Given this list of marker genes Ywhaz, Lama5, Clasp1, Ptprf, Dnm1l, Zfp804a, Mark1, Sybu, Ptpn1, Gripap1, Drd2, Dmpk, Cdh4, Actn4, Actr3, Six1, Caprin1, Adgrb1, S100a10, Epha7, Unc13b (NCBI Gene Id 230089), Lrrk2, Arhgap33, Chrnb1, Cldn34b2, Grm5, Nedd8, C5ar1, Wasf2, Gabra2, Cnksr2, Tln2, Cap1, Cldn11, Tenm3, Epha2, Fam107a, Gjc1, Egln1, Ppfia3, Amigo3, Glrb, Lrp8, Anapc2, Tiam1, Cldn12, Abi2, Tnf, Thy1, Homer1, Erbb2, Nrn1, Cacna1a, Cldn10, Septin7, Slit2, Snapin, Cntnap1, Cldn1, Setd5, Epb41l5, Asic1, Cldn19, Rab29, Prickle1, Cldn22, Cntn5, Ror2, Xlr3b, Arf4, Nbea, Trim47, Ptpro, Amot, Ptpra, Prkca, Pfn2, Rab39b, Sez6, Efna5, Dbn1, Wdpcp, Tgfbr1, Pdzrn3, Stau1, Myo5a, Nrxn2, Itga3, Plxna2, Fbxo45, Nr1h4, Plxna3, Itgam (NCBI Gene Id 16409), Picalm, Nefl, Flcn, Insyn1, Lsr, Arhgap6, Ace2, Vhl, Lin7a, Tnc, Kif5b, Samt3, Pcdhgc5, Grip2, Gpc4, Zdhhc17, Itgb1, F11r, Ogt, Cpeb3, Gabra5, Xlr4a, Rac1, St8sia2, Grn, Sncg, C3, Colq (NCBI Gene Id 382864), C1ql3, Pard3, Hspa8, Sdcbp, Ctbp2, Chmp2b, Apbb1, Il1rapl1, Sema4c, Gphn, Cacna2d2, Ocel1, Ptprs, Asb17, Sdk2, Plxnb1, Fyn, Htr4, Cdh20, Arhgap39, Asap1, Nrg2, Prmt3, Myh9, Tjp3, Lgmn, Tgfb1, Prtn3, Rab3a, Cdkl5, Nrg1, Gjb2, Lypd11, Nfatc4, Epha5, Amigo1, Sptb, Gsg1l, Ube3b, Igsf21, Srpx2, Pclo, Ildr1, Pard6a, Whamm, Nphp4, Plec, Slc12a5, Myo6, Pdlim5, Gja5, Slc39a9, Rock1, Camk2b, Lrp1 (NCBI Gene Id 16971), Cd177, Nptxr, Nedd4 (NCBI Gene Id 639396), Pip5k1a, Jup, Lrrc4, Cadm4, Arc, Sptbn4, Vangl2, Oxtr, Plxnb3, Rapgef1, Clasp2, Aplnr, Zfp365, Pdpk1, Malat1, Nf2, Mtss1 (MTSS I-BAR domain containing 1), Csf1r, Sorbs2, Actn3, Rer1, Akap5, Lrrtm4, Cldn18, Il10, Sort1, Rap1b, Rims3, Rph3a, Usp9x, Col16a1, Clstn3, Ppfia1, Pls3, Ctnna1, Xirp2, Numb, Lrrn3, Il10ra, Mapk14, Asic2 (NCBI Gene Id 637557), Micall2, Hdac7, Ank3, Gabra3, Lingo4, Nrp1, Rapgef4, Cdh11, Lamc1, Lims1, Ghsr, Src, Adgrl2, Fgfr1, Snap91, Rhob, Hopx, Ppfibp2, Cx3cr1, Mylk3, Cdk5, Nf1, Prickle2, Slit1, Smad3, Oxt, Ache, Ppm1f, Pin1, Adgrb2, Elavl2, Srgap3, Psd, Sncb, Cdh5, Cntnap2, Lats1, Adnp, Kif1a, Rims2, Dvl1, Sema4a, Slc30a1, Shisa6, Grin1, Mpz, Palld, Ccdc39 (NCBI Gene Id 99728), Dock10, Agt, Grin2a, Igf1r, Zdhhc15 (zinc finger, DHHC domain containing 15), Abl2, Syn1, Rhoa, Lrtm1, Abi3, Cd47, Chrna7, Sdc4, Ntn1, Map4k4, Clstn2, Ptk2, Rhoc, Ldb1, Ephb1, Xlr4b, Ptpn11, Cdh10, Cdh6, Tnr, Arhgap22 (NCBI Gene Id 239027), Mapt, Adgrl1, Zdhhc8, Adgre5, Rdx, Stk38l, Dok7, Podxl, Musk, Ghrl, Pak3, Als2, Cript, Vmp1, Csmd2, Cdh1, Wnt3a (NCBI Gene Id 22416), Sema3a (NCBI Gene Id 20346), Crtac1, Cdh12, Sarm1, Lama3, Cap2, Il17a, Wasf1, Cit, Cbln2, Nedd9, Specc1l, Dst, Prmt8, Tns1, Crmp1, Dab2ip, Cdh26, Agrn, Pdzd11, Flrt3, Lin7c, Ky, Cldn34c3, Itgb1bp1, Cdh15, Cd9, Il1rap, Mdga1, Mef2c, Fermt2, Snca (synuclein, alpha), Fmn1, Gna13, Baiap2, Dock1 (dedicator of cytokinesis 1), Stk38, Afg3l2, Myo9a, Tpbg, Ppfia2, Cdh2, Prkcz2, Slc7a11, Chrnb2, Cdk5r1, Fgf13, Cd2ap, Slk, Kcnk13, Pafah1b1, Myo5b, Iqsec1, Nckipsd, Crkl, Eif4g1, Vcp, Irx3, Mpp7, Ntrk1, Elfn2, Taok2, Alox12b, Ptpn23, Lmx1a, Plxnd1, Kirrel3, Lin7b, Afdn, Lingo2, Itgb3, Cldn13, Cdh22, Cldn7 (claudin 7), Csk, Mecp2, Slc6a1, Ramp2, Slitrk2, Nrg3, Pfn1, Ngef, Acvrl1, Srcin1, Dsg3, Vldlr, Lamb2, Ceacam1 (CEA cell adhesion molecule 1), Esam, Unc13a, Aloxe3, Adgrf1, Gja1, Shank3, Cacnb4, Septin11, Flrt1, Cdc20, Magi2, Lrrtm3, Dusp3, Psen1, Adgrl3, Rab8b, Filip1, Lzts3, Sipa1l1, Col4a1, Synpo, Sema4d, Dsp, Samt1b, Tgfb3, Lypd10 (NCBI Gene Id 381977), Ezr, Cldn2, Cldn23, Gabrb3, Crk, Mmp14, Cldn34a, Zdhhc12, Plxna4, Spg11, Nlgn1, Slc25a46, Gabrb2, Inava, Nectin1, Robo2 (roundabout guidance receptor 2), Zdhhc2 (NCBI Gene Id 76202), Kifc3, Tlr2, Ptprk, Tgfb2, Frmpd2, Myoc, Ugt8a, Dlg1, Erc2 (NCBI Gene Id 52497), Flot1, Prkci, Lmx1b, Dscam, Nfasc, Pkn2, Nectin3, 2610042L04Rik, Actr2, Chrd, Cldn14, Lrp4, Pum2, Bdnf, Ptk2b, Sh3gl2, Kprp, Grhl2, Negr1, Rbmx, Hdac6, Rap2a, Ppfia4, Lamtor2, Marcks, Ube2v2, Limch1, Cldn34c5, Cabp1, Igsf9b, Fnta, Perp, Lrfn4, Nedd4l, Cldn34c1, Wnt4, Gjb6 (NCBI Gene Id 52881), Dlgap3, Bsn, Ajuba, Cyfip2, Neurod2, Coro1c, Bcan, Ext1, Dlg4 (NCBI Gene Id 13385), Tanc2 (NCBI Gene Id 77097), Vcl, Plxna1, Nae1, Mtmr2, Slitrk6, Efna1, Hnrnpk, Cpne6, Lrrtm1, Marveld2, Kdr, Arhgap44 (NCBI Gene Id 216831), Plekha7, Cldn34b1, Igsf11, Fzd5, Pdxp, Ctnna2, Nrxn3, Sema3f (sema domain, immunoglobulin domain (Ig), short basic domain, secreted, (semaphorin) 3F), Slitrk5, Fbf1, Epha4, Bmp6, Nphp1, Hnf4a, Ins1, Dock4, Nos1ap, Zc4h2, Arhgef15, Abhd17b, Sparcl1, Elfn1, Hrg (NCBI Gene Id 94175), Plppr4, Cdh24, Shank1, Caskin1, Nrcam, Srf, Crb3, Lrtm2, Farp1, Slc1a1, Trpv4, Itga2, Lrp5, Cntn6, Fer, Pick1, Dgkb, Rac3, Add2, Cldn5, Ikbkb, Wnt11, Wnt5a, Cacng2 (calcium channel, voltage-dependent, gamma subunit 2), Itgav, Zfp703, Lnx1, Mesd, Tek, Rab13, Col17a1, Neurl1a, Nphs1, Mfn1, Ckap5, Abl1, Pcdh17, Arf1, Actb, Eef2k, Lrfn2 (leucine rich repeat and fibronectin type III domain containing 2), Nrp2, Snai2, Syngap1, Kif2c, Heg1, Efnb3, Rap1a, Iqsec3, Mdga2, Shisa7, Slc8a3, Etv5, Cldn34c4, Lims2, Gabra6, Rps6, Dlg5, Psen2, Cav1, Dgkz, Dkk1, Snta1, Patj, Tanc1, Grm6, Dhx36, Marveld3, Pak2, Cttnbp2, Fzd1, Chat, Nfia, Itsn1, Gabra4, Smad7, Lhfpl4, Nptx1, Cux2 (cut-like homeobox 2), Nefh, Mycbp2, Opa1, Syndig1, Cldn24, Pak1, Cdh7, Rims1, Prrt1, Sptbn2, Amigo2, Atp2b2, Grhl1, Gpr158, Capza1b, Grid2, Kcnj8, Tesk2, Cdh17, Six4 (NCBI Gene Id 20474), P2rx2, Apoe, Abhd17a, Enpp2, Epb41l3, Drd1, Poldip2, Gria1, Cdh9, Sez6l, Samt2, Sparc, Gsk3b, Ace, Pmp22, Ncan, Ctnnb1, Fn1, Rock2, Ssh1, Ppp1r9b, Zmynd8, Tmigd1, Cbln3, Actg1, Rtn4r, Dnaja3, Insr, Snai1, Gnpat (glyceronephosphate O-acyltransferase), Dmtn, Rhog, Cfl1, Peak1 (pseudopodium-enriched atypical kinase 1), Icam5, Cldn4, Cbln4, Pkp1, Sh3bp1, Itgb4, Ppfibp1, Akt1, Palm, Gabra1, Mapre2, Adam10, Tuba1a, Dab1, Lrit3 (leucine-rich repeat, immunoglobulin-like and transmembrane domains 3), Dctn1, Disc1, Dixdc1, Dtnbp1, Srgap2, Bhlhb9, Itga5, Slitrk4, Rest, Bcl2, Dsg2, Lrrc4b, Ptpn13, Pkp3, Prkch, Nlgn2, Cntn2, Abhd17c, Pdgfb (platelet derived growth factor, B polypeptide), Cldn3, Il1rapl2, Kirrel1, Gjd3, Npas4, Pof1b, F2rl1, Pkp2, Trem2, Ago2, Rps6ka5, Dlgap4, Hip1r, Cldn9, Cdhr18, Cldn34b3, Large1, Daam1, Dlg2, Cln3, Camk1, Chrdl1, Ins2, Cdh18, Nrxn1 (NCBI Gene Id 68042), Vegfa, Rtn4, Igsf9, Camkv, Ptprj (NCBI Gene Id 98976), Lrrn1, Epha3, Cdc42, Caprin2, Capza1, Fcgr2b, Pxn, Robo1 (roundabout guidance receptor 1), Fkrp, Gdnf (NCBI Gene Id 14573), Sorbs1, Thsd1, Ppp1r9a, Ntng1, Lrrtm2, Thbs2, Frrs1l, Wasf3, Lrrc4c, Ccm2 (NCBI Gene Id 216527), Dcx, Tubb5, Htr1a, Rapgef2, Frmpd4, Pkhd1 (polycystic kidney and hepatic disease 1), Dact1, Clstn1, Cldn8, Mpp2, Ptprd, Prkaca, Gap43, Mfn2, Tjp1, Ephb2, Snx27, Sema7a, Abi3bp, Nlgn4l, Snap25, Sdf4, Pecam1, Arhgef7, Klk8, Dapk3, Wnt7b, C1qc (NCBI Gene Id 12262), Arhgef9 (CDC42 guanine nucleotide exchange factor 9), Dsc1, Tln1, Fgf7, Cldn17, Col4a5, Lzts1, Cldn34b4, Rims4, Map1b, Shank2, Mpdz, Myh10, Bhlha15, Rapsn, Dclk1, Vps35, Pcdhgc4, Ston1, Iqsec2, Dusp22, Bcr, Ect2, Appl1, S1pr2, Ephb3, Samt1d, Adgrb3, Cldn16, Tbcd, Ntrk2, Add1 (adducin 1), Dlc1, Ntrk3, Arl2, Adgrl4 (NCBI Gene Id 76321, adhesion G protein-coupled receptor L4), Cc2d1a (coiled-coil and C2 domain containing 1A), Gpbar1, Plxnb2, Grid1, Flna (NCBI Gene Id 245705), Il1b, Lrfn5, Abcc8 (ATP-binding cassette, sub-family C member 8), Apod, Dip2a, Gpm6a (glycoprotein m6a), Sdk1, Nptn, Wdr1, Cldn6, Chd4, Shroom2, Flrt2, Samt2b, Gpm6b, Get1 (guided entry of tail-anchored proteins factor 1), Tbx5, Stau2, Cldn34c6, Cxadr, Pcdh8, Erbb4, Erc1, F2r, Pdcd6ip, Pgrmc1 (NCBI Gene Id 53911), C1qb, Slc18a3, Iqgap1, Gdf2, Jam3 (junction adhesion molecule 3), Grem1, Tsc1, Cldn34c2, Ube2m, Cldn34d, Actn1, Whrn, Gabre, Ctnnd2, Vstm5, Gabrg2, Gabrg1, Rab17, Nlgn3, Lrrc24, Itpka, Cdh8, Coro2b, Slitrk1, App, Slitrk3, Hapln4, Camsap3 (NCBI Gene Id 69697), Dnm3, Arf6, Tsc2, Rhod, Cdh3, Svep1, Wasl, C1ql1, Lrfn3, Gja10, Cdh13, Ptn, C1ql2 (NCBI Gene Id 226359), Cyfip1, Mark2, Hmcn2, Cttn (cortactin), Cacna2d3, Cgn (NCBI Gene Id 99764), Carmil3, Cadm1, Hnrnpm (heterogeneous nuclear ribonucleoprotein M), Ophn1, Phldb2, Hipk1, Syn2, Strn4, Efnb1, Tjp2, Slc8a2, Vezt, Ntng2, Pcdhgc3, Chrna1, Sigmar1, Slc9a6, Dag1, Ube3a, Rimbp2, Macf1, Fgfr2, Elmo1, Drp2, Samt4, Fgf22, Cntnap4, Lrfn1, Dbnl, Cask, Rhpn1, Cacna1s, Plxnc1, Efnb2, Pik3r1, Wnt7a, Prnp, Ocln, Pkp4, Rheb, C1qa, Ina, Rcc2, Tmem108, Numbl, Fzd9, Grin2b, L1cam, Myo1c, Rps6-ps4, Cbln1, Sema3e, Kalrn, Pten, Cdh19, Actn2, Lgi2, Ptprt, Gabrg3, Dock7, Cldn15, Syn3, Fscn1, Reln, Tenm4, Sez6l2, Ajm1, here is a description of the gene set: A process that is carried out at the cellular level which results in the assembly, arrangement of constituent parts, or disassembly of a cell junction. A cell junction is a specialized region of connection between two cells or between a cell and the extracellular matrix. studied in species Mus musculus Mouse Gene Set: GOBP_CELL_JUNCTION_ORGANIZATION